Given this list of marker genes UBL5 (ubiquitin like 5), RIPOR1, ZNF148, RALGPS2 (Ral GEF with PH domain and SH3 binding motif 2), SAMD8, CTBP1, SELPLG, SRI, RHOB, NUP210, PTEN, DPM1, STX1A, RCAN3, POR, RBM18, SLC52A3, E4F1, ERRFI1, KLHDC3 (kelch domain containing 3), SAMHD1, RBM7, MED1 (mediator complex subunit 1), EPCIP, SGK3, LGALS3BP, TSPAN13, FNDC3A, TMUB2, METTL27, DDHD1, CLTA, BCAS3, GATAD2B, SLC41A1, DNAJC3, SHF, ABL1, QPCT, DGAT1, NECAP2, OSTF1, CRIPT, DIPK2A, SHE, ATP6AP2, MPP1, KDM4B, SYK, SGIP1, SYVN1, DENND6A, SEC16A, VPS37C, CRLF2, IGF2R, MED14 (mediator complex subunit 14), CSNK1G1, ZKSCAN5, ZFP1, ARF4, PEA15, TAMALIN, PARP8, PDE1B, PLEC, DNAJA1, SH3GL1, CHD7, SLC23A3, PLAUR, SQOR, GBA1, LY75, KLF3, CAPZA1, STMN3, MAN2C1, ARHGAP1, SEC11A, MR1, SMC4, ARL4A, JUN, VCL, LIMD2, TNFAIP8L1, MARK2, TRPV4, DAPP1, PSTPIP2, LIPA (lipase A, lysosomal acid type), WSB1, TMLHE, PCNX3, ANO10, GSTK1, PKD1 (NCBI Gene Id 5310), QPRT, ACTR10, PRX, GRIPAP1, RAC2, PPP1CC, CYBC1, MORF4L2, MDM2, KIAA0319L, HOXD9, CAPN2, HIF1A, HOXD8, ACBD3, NR4A3, TDP2, HERPUD1, HBS1L, CTDSP1, TRPC4AP, LAIR1, SCGB1A1, RBMX, NCOR1, PHIP, ZNF830, SFXN3, HLA-DRB1, UPF2, FAM53C, IRF9, NFIA, USP7 (NCBI Gene Id 7874, ubiquitin specific peptidase 7), HS3ST3B1, TBCEL, CTSS, QRICH1, BEX3, ZRSR2, ETS1, TUBGCP5, ACOX1, PCSK7, PARP12, PDGFRA, IFI35, RNF7, RAB6A, JCHAIN, LONP2, XYLT2, SEMA4F, TTLL3, ZNF264, GLIPR1, SPOP, ZBTB18 (NCBI Gene Id 10472), PRDX6, QKI, ARRDC1, ALKBH4, NFYC, XIAP, LMBRD1, TMEM80, OAZ2, IL16, MYO9B, RDH5, ABCB1 (ATP binding cassette subfamily B member 1), SPG11, ATAD2B, SPPL3, ZNF764, ACVRL1, SMC5, SLAIN2, CARD14, RPS16, IVNS1ABP, IDH1, DOK2, ICOS, PHF8, PDK2, RAB10, TAF13, MIB2, B2M, CHIC2, CD3E, ANGEL2, GUCA1B, CR1L, MAN1A2, MAP2K6, ERN2, ARHGDIB, DLG1, TOX, FASLG, here is a description of the gene set: Genes up-regulated in hematopoietic stem cells: wildtype versus IKZF1 knockout. species: Homo sapiens Human Gene Set: GSE15330_WT_VS_IKAROS_KO_HSC_UP from publication Ng SY, Yoshida T, Zhang J, Georgopoulos K (PMID 19345118) Regulation of lineage potential and transcriptional priming by Ikaros. New insight is provided into a bivalent regulation of lineage priming in the HSC and its lympho-myeloid restricted progeny the LMPP by the lymphoid lineage-determining factor Ikaros Whereas Ikaros is responsible for the activation of a cascade of lymphoid expression programs and for the establishment of lymphoid potential from the HSC to the LMPP it is also responsible for the repression of stem cell and erythroid genetic programs that are incompatible with further lineage restrictions emanating from the LMPP